The following is a description of a gene set: studied in species Mus musculus Mouse Gene Set: GOBP_POSITIVE_REGULATION_OF_CELL_CYCLE_CHECKPOINT Any process that activates or increases the frequency, rate or extent of cell cycle checkpoint., and this is the list of marker genes: Incenp, Pcid2, Tpr, Birc5, Map3k20, Aurkb, Ndc80, Dync1li1, Knl1, Tti1, Mad1l1, Gen1, Cdca8, Xrcc3, Mad2l1, Ccar2, Prox1